Given this list of marker genes FRMD5, GAP43, NRP2, TMT1B, EGR1, JAG1, CD44, DIRAS3, VMP1, TNC, AKAP12, S100A16, PDLIM4, EMP1, MIR4435-2HG, LYST, CLIC4 (NCBI Gene Id 25932), ANXA1, ZYX, F3, ACTN1, IGFBP3, ELL2, CAMK2D, PLAT, CREB5, SAMD4A, BCAT1, IGF2BP2, TNFRSF12A, PGM2L1, IL1RAP, KLHL4, RCAN1, GADD45A, ANXA2, IGFBP7, WWTR1, SLC4A7, NAMPT, VCL, CADPS, ADAMTS9-AS2, LMNA, GFAP, VIM, HIVEP3, CYTOR, GNG12, SCG2, here is a description of the gene set: Genes upregulated in subsets of cells of a given type within various tumors species: Homo sapiens In this study, an extensive analysis was conducted to define meta-programs (MPs) capturing intra-tumor heterogeneity across a spectrum of tumor types. The approach utilized non-negative matrix factorization (NMF) to analyze each cell type separately within individual tumor samples. This involved the analysis of malignant cells, macrophages, fibroblasts, endothelial cells, epithelial cells, T-cells, and B-cells. NMF was executed with varying parameter values (K=4, 5, 6, 7, 8, 9), thereby generating 39 programs for each cell type per sample. Each NMF program was summarized by the top genes based on NMF coefficients.\nRobust MPs were then delineated for each cell type using a set of stringent criteria, including recurrence within the same tumor, similarity to programs in other tumors, and non-redundancy within a tumor. Subsequently, these robust NMF programs were clustered (per cell type) based on Jaccard similarity, leading to the identification of MPs associated with each cell type.\nTo enhance the quality of the MPs, a refinement steps were undertaken, involving the removal of MPs suspected of reflecting low-quality data (with an overrepresentation of ribosomal proteins or mitochondrial-encoded genes), single-study inclusion, or similarity to miss-annotated cell types. Human Gene Set: GAVISH_3CA_MALIGNANT_METAPROGRAM_16_MES_GLIOMA from publication Gavish A, Tyler M, Greenwald AC, Hoefflin R, Simkin D, Tschernichovsky R, Galili Darnell N, Somech E, Barbolin C, Antman T, Kovarsky D, Barrett T, Gonzalez Castro LN, Halder D, Chanoch-Myers R, Laffy J, Mints M, Wider A, Tal R, Spitzer A, Hara T, Raitses-Gurevich M, Stossel C, Golan T, Tirosh A, Suvà ML, Puram SV, Tirosh I (PMID 37258682)